Given this list of marker genes FGF13, SEMA6D, ESRRB, LZTS3, GRIK1, EEF1A2, CNST, GPR85, PRPH, CHN2, SRL (sarcalumenin), RAB9B, CHRNB4, TSTD1, PIP4P2, ALCAM, RBMS3, GDAP1, RHOU, MPP2, GREM2, ARK2C, RTN1, RUNDC3A, PMFBP1, GRM1, HMGCLL1, ATP1A3, NAPB, GNG3, STXBP5, PIANP (PILR alpha associated neural protein), CACNB3, SV2C, CHRNA3 (cholinergic receptor nicotinic alpha 3 subunit), GDAP1L1, ADGRA1-AS1, TAGLN3, SNCB, CEND1, NEIL1, AHNAK2, FAM131B, RAB11FIP4, PAFAH1B3, ST8SIA3 (NCBI Gene Id 83169), GAP43, ZNF33B, NEFL, NYAP1 (neuronal tyrosine phosphorylated phosphoinositide-3-kinase adaptor 1), ABCC8, PHOX2B (paired like homeobox 2B), FNDC5, LCOR, DACH1, TLCD3B, PRMT8, PCDHA7, TMEM169, RAB15, SNX1, KLC1, CADM3, EPHA3, PPP2R2C, NLN, KIFAP3, SULT4A1, SEMA3E, SLC1A4 (NCBI Gene Id 6509), ADCY2, ETFB (electron transfer flavoprotein subunit beta), FSTL5, LYST, SH3PXD2A, JUP, ABLIM1, CHGA, STMN3, ASNS, NIPA1, FGF1, SCN9A, RAPH1, PLCL1, MSANTD3-TMEFF1, MYO5A, TMEM121B, IRX3, CACNA1C, STXBP1, GARNL3, ISL1, KIF26A, THSD7B, SCRT2, TTC9B, DOK5, ELOVL4 (ELOVL fatty acid elongase 4), NALF1, ACOT7, DOK6, FGF9, ENO2, ACTL6B, TRIM36, SNORD116-1, MAP1LC3A, RIPPLY2, KHDRBS3, PCBP4, BEX5, SNORD116-24, BACH2, ISL2, SNCA, EDIL3, GABRA5, EYA1, SHTN1, TRHDE, ATP11C, PRRT2, ARG2, CTNNA2, DPYSL3, GPRIN1, FNDC9, SRRM3, MT1F, BEX2, ECEL1, ATP2B2, INHBA-AS1, NICOL1, DTD1, TMEM255A, CNTNAP2, KIF3A, PHF21B, CLVS1, ZC2HC1A, GABRG2, PEX5L, LINGO1, PFKM, CACNG2, MAP4, NETO1, ADAM22, FABP6, PLXNA4, TUBB2A, CTXN3, RXRG, MAB21L2, SYT2, RUSC1, C1QL2, ELAVL4, SLC4A8, MIR218-2, SCG5, FSD1, GPR155, SST, UBE2QL1, PLPPR4, ZFHX3, PPP2R2B, MAST1, TMEM59L, DOK4, CNTN4, SNAP25, CSMD3, MDGA2, RBFOX2, NTRK1, PLCB1, FAIM2, PPFIA2, DNM1, ELAVL2, SMPD3, ATCAY, SYN3, STMN4, TUBB2B, CNTN2, PHOX2A, TENM3, TRIM8, SCN8A, ABCA3, VGF, CLUL1, OSBPL6, DMTN, PCDH9, SYT4, CAP2, GLRA2, SEMA3D, SLC5A7, CCDC184, TMX4, RAPGEF5, SEZ6L2, HTR3A, NMNAT2, TSPAN7, BASP1, SLC18A3, VSTM2A, CELSR3, KCNMA1, OCIAD2, RUFY2, NEFM, MCF2L, XKR4, ACSL4, ATP2B1, LRFN5, CPNE8, RCOR2, VSTM2L, SCN3A, EPB41L1, SPINT2, OLFM1, ISL1-DT, TUBA1A, CADM1, AATK, PHACTR3, PLPPR2, MAP6, UNC79, MAP2, LRRN3, LRRTM2, FNBP1L, PDP1, MAPK6, BRINP2, SRRM4, CD2, NFASC, APC2, PLCXD3, KIFC2, MPP3, RELN, CXADR, AKR1C1, OGDHL, MLLT11, CHRM2, TRPV2, SLITRK4, GNG2, JPH3, ADGRB3, ANK3, P2RX3, TLE4, NSG1, SIM2, AKR1C2, PDE1B, SP5, CCDC112 (coiled-coil domain containing 112), INA, GNAL, DBH, ATL1, VAT1L, ARFGEF3, ACVR1B, TENM2, FAR2P2, TMOD2, CELF6, KIF5C, TCEAL5, NELL2, CRMP1, REEP1, PRKACB (NCBI Gene Id 5567), JPH4, SVOP, L1CAM, CORO2A, GSG1L, FAXC, MAP3K9, CD24, ATP6V1A, MAP7D2, CRNDE, TIGD3, SNCG, GLRX, SEPTIN3, KCNH8, SHROOM2, SLC38A1, ENSG00000248540, FRY, UCHL1, STAC, ANK2, NRP2, APLP1, MEG3, LZTS1, RNF157, MMP24, GPR176, RAB6B, BZW2, SLC6A15, SLIT3, DUSP26, ESRRG, SMAP2, BEX1, PID1, TUBB3, LHX4, POU6F2, PSD2, DGCR6, C11orf87, RAB3A, CTXN2, ADCY1, DCX, MYT1, N4BP3, TLN2, DOCK4 (dedicator of cytokinesis 4), HSPA12A, KIF21A, PCDH7, ZMAT4, SLITRK1, C1orf35 (NCBI Gene Id 79169), CNTNAP4, ELAVL3, MAP1B, PRKAR2B, SPOCK3, RUNDC3B, ST18, CPEB3, INSYN2A, DNAJC6, CELF3, MIR7-3, DNM3, STMN2, GRIA4, CLCN4, PLXNA3, BSN, MAPRE3, SEPTIN6, GPC2, RASA4, FADS3, SYP, SEMA4D, HCN3, STMN1, B4GALNT1, C17orf75, SEMA3C, SEMA3A, MGAT5, CASZ1, CYP4X1, MCF2, RIMBP2, NELL1, SYT7, RBFOX1, here is a description of the gene set: species: Homo sapiens from publication La Manno G, Gyllborg D, Codeluppi S, Nishimura K, Salto C, Zeisel A, Borm LE, Stott SRW, Toledo EM, Villaescusa JC, Lönnerberg P, Ryge J, Barker RA, Arenas E, Linnarsson S (PMID 27716510) Cell types are named using anatomical and functional mnemonics prefixed by 'm' or'h' to indicate mouse and human respectively: OMTN, oculomotor and trochlear nucleus; Sert, serotonergic; NbM, medial neuroblast; NbDA, neuroblast dopaminergic; DA0-2, dopaminergic neurons; RN, red nucleus; Gaba1-2, GABAergic neurons; mNbL1-2, lateral neuroblasts; NbML1-5, mediolateral neuroblasts; NProg, neuronal progenitor; Prog, progenitor medial floorplate (FPM), lateral floorplate (FPL), midline (M), basal plate (BP); Rgl1-3, radial glia-like cells; Mgl, microglia; Endo, endothelial cells; Peric, pericytes; Epend, ependymal; OPC, oligodendrocyte precursor cells. Human Gene Set: MANNO_MIDBRAIN_NEUROTYPES_HOMTN